The following is a description of a gene set: Human Gene Set: GSE21670_IL6_VS_TGFB_AND_IL6_TREATED_STAT3_KO_CD4_TCELL_DN species: Homo sapiens Genes down-regulated in CD4 T cells with STAT3 knockout: IL6 versus TGF beta and IL6. STAT3, an essential transcription factor with pleiotropic functions, plays critical roles in the pathogenesis of autoimmunity. Despite recent data linking STAT3 with inflammatory bowel disease, exactly how it contributes to chronic intestinal inflammation is not known. Using a T cell transfer model of colitis we found that STAT3 expression in T cells was essential for the induction of both colitis and systemic inflammation. STAT3 was critical in modulating the balance of T helper 17 (Th17) and regulatory T (Treg) cells, as well as in promoting CD4+ T cell proliferation. We used chromatin immunoprecipitation and massive parallel sequencing (ChIP-Seq) to define the genome-wide targets of STAT3 in CD4+ T cells. We found that STAT3 bound to multiple genes involved in Th17 cell differentiation, cell activation, proliferation and survival, regulating both expression and epigenetic modifications. Thus, STAT3 orchestrates multiple critical aspects of T cell function in inflammation and homeostasis. from publication Durant L, Watford WT, Ramos HL, Laurence A, Vahedi G, Wei L, Takahashi H, Sun HW, Kanno Y, Powrie F, O'Shea JJ (PMID 20493732), and this is the list of marker genes: IFIT1B, CXCR5, PACSIN1, SELENOP, IMMP1L, TOX, NR4A2 (nuclear receptor subfamily 4 group A member 2), RYBP, CCND2, INO80, CPXM2, MSL1, TMIE, PNISR, IRF7, REEP5, KRT85, ZCCHC12, HELZ2, HSF4, HPS4, FOXJ2, DNAJB14, XPR1, ZNF436 (NCBI Gene Id 80818), ZCCHC13, CCDC112, PRKCH, SLC45A3, CNNM3, DAAM2, BMPR2, PANK4, RETREG2, PAXBP1, RTP4, SKP1, MTF2, CDK17, PAM, RELB, VWA3A, FCSK, KCNE1, ZNF579, PLCB2 (NCBI Gene Id 5330), PIK3R3, PARP11, PHLDA1, RAMP2, DENND2A, IRF8, PABPC1, PTPRS, SPINT2, TMX2, EFNA3, DNAJA1, DENND1A, PLD3, ZBTB4, METTL2B, PLEKHA1, RFX5, HLA-DOA, NDFIP2, PNMA2, MXD4, KIRREL3, TOR3A, SLC6A5, PCGF5, NEK7 (NCBI Gene Id 148565), SON, ZKSCAN3, PARP6, RAMP1, PLXDC2, PEX6, TNFRSF18, ATF5, NOCT, ITM2A, CCNL1, MLPH, FOXG1, NICN1, CGAS, MUC4, ARMCX2, CAMTA2, NR4A1, C3orf80 (NCBI Gene Id 401097), DUSP2, BLTP2, AMMECR1L, KIF26B, ZBTB20, AAMDC, ARID1B, PML, PPIP5K1, GZF1, ADAMTS7, TSC22D4 (TSC22 domain family member 4), SSH1, CCDC89, GRAMD1A, KXD1, CNN3, ATXN10, BSDC1, CEP350 (centrosomal protein 350), GPM6B, ABCA1, GADD45G, CTPS2, TUT4, MOCS3, GYG1, SPEN, EOMES, GPR39, EIF4G3, FCRL1, UBIAD1, KCNN4, EGR3, TRIM21, SLAMF1, RNF2, DUSP14, PLD2, ZNF711, RAPGEF6, JADE2, GLCCI1, SESN3, IGF2R, IFIT1, TDRD7, NARF, CD320, DECR2, HSD17B11, SSH2, TSPAN32, CCDC141, DAXX (NCBI Gene Id 1616), SPAG17, PRKRA, ISG15, DCAF11, IFI35, PLEKHA8, RC3H2, RGL2, IL27RA, NRIP1, KDM5B, DMAC2L, RASGRF2, KANSL3, GBP6, RPS27, NCF4, ANGPTL2, ELK3, IFFO2, ADRB3, TRRAP (NCBI Gene Id 8295), CD37, ATOSA, THRSP, DCTN1, RCOR3, MAPK8IP3, C3orf33, LCLAT1, PLOD1, AQP2, CUX1, EDC3, TIMM17B (NCBI Gene Id 10245), NDRG1 (N-myc downstream regulated 1), TRIM72, IQSEC1, PITPNM1, SPTBN1, GPR34, PURA, BASP1, B2M, LYPD6B, SMURF2, PRDM15, MESD, HOXD10, GDNF